The following is a description of a gene set: Human Gene Set: GOMF_MACROMOLECULAR_CONFORMATION_ISOMERASE_ACTIVITY studied in species Homo sapiens Catalysis of a reaction that alters the macromolecular conformation of a molecule., and this is the list of marker genes: TOP3A, MYH10, POLQ (NCBI Gene Id 29043), DDX55, FBH1, DDX11L8, DYNLRB1, RUVBL2, MYO15A, SPAST, SNRNP200, MYO9B, RFC4, CHD3, BTAF1, STARD9, KIF1C, DDX52, DDX17, MYO6, BLM, DDX28, CHD9, FXR1, WRNIP1, MYH7, KIF6 (kinesin family member 6), KATNA1, KIF17, DHX38, DDX25, CHD6, MYO3A, RAD54L, SPO11, DICER1, KIF4A, DHX15, DHX32, DQX1, KIF28P, RFC5, DNAI2, KIF1B, DDX12P, RUVBL1, DDX50, XRCC6, ASCC3, MYH1, DHX30, RTEL1, DDX51, KIF21A, RECQL5, CENPE, DDX1, KIF24, DDX54, YTHDC2, KIF13B, DDX59, DNAH8, KIF2C, MYL6, KIF12, FANCM, SMARCA4, MYO5C, DDX53, MYH3, ERCC6, KIF27, SMARCAD1, HFM1, PSMC4, CFTR (CF transmembrane conductance regulator), DDX24, SMARCA2, RAD54B, DNAH5, KIF1A, MYO1A, SKIC2, RAD51, DDX23, KATNAL2, TOP2B, KIF9, NAV2, KIF4B (kinesin family member 4B), DNAH9, MCM4, MCM5, MYO5B, KIF20B, KIF11, CHD7, PIF1, DHX37, TOP2A, SETX, CHD1, DNA2, TOP3B, TNNT2, MYO1H, MYO1C, MYH6, WRN, MCM8, MYH7B (myosin heavy chain 7B), KIF13A, MCM9, DNAH6, DDX3X, DNAL4, KIF2B, CHD8, DDX18, KIF3C, KIF18B, MYH2, DNAH1, KIF19, KIF23, DDX39A, KIF26A, MYO9A, IGHMBP2, EIF4H, RAD54L2, TP53, MCM7, ZRANB3, MRE11, MYH15 (myosin heavy chain 15), MYO1D, HELZ, DDX4, CHD4, KATNAL1, DDX3Y, KIF14, DHX36, SHPRH, MOV10, KIF18A, KIF3A, HELB, DDX27, DDX11, APPBP2, ZGRF1, DHX33, DNAH3, DDX60 (NCBI Gene Id 55601), FIGNL2, KIF22, CHD5, MYH13, IFIH1, TTF2, SRCAP, ERCC6L2, MYO7B, KIFC1, MYO1B, HELQ, MYH9, ERCC2, UPF1, PSMC2, DYNC2H1, AQR, ACTC1, DHX8, FMR1, SLFN11, MCM6 (minichromosome maintenance complex component 6), MCM2, EIF4A2, HLTF, DDX41, KIF5A, DNAH10, DHX29, IQCA1, DNHD1, TDRD12, EIF4A3, XRCC5, DDX56, DDX19A, DDX39B, DHX35, DDX19B, MYH4, DHX16, IQCA1L, DYNC1I2, TOP1, FIGNL1, RAD50, DSCC1, DNAH17, MYO3B, DNAH2, DDX21, FIGN, MOV10L1, PSMC1, KIF2A, PSMC3, DHX40, DDX47, KIF3B, DNAH12 (NCBI Gene Id 8679), DYNC1I1, EIF4B, DNAH14, MYO1F, RFC2, DDX6, KIF5B, CHD2, ATRX, TDRD9, DHX34, MYO7A, SMC3, CHD1L, MYO19, DHX57, EP400, MCM3, KIF26B, KIFC3, DDX5, HELLS, DDX10, KIF25, PSMC5, EIF4A1, DDX46, SMARCA5, DYNLRB2, ERCC6L, DNAH11, BRIP1, DDX42, KIF7, RFC3 (replication factor C subunit 3), ZNFX1, KIF5C, KIF21B, KIF16B, MYH11, CHTF8, TOP1MT, RECQL, MYH14, DHX58, DHX9, SMARCAL1, G3BP1, DDX31 (NCBI Gene Id 64794), KIF20A, SUPV3L1, DDX60L, DNAH7, SMARCA1, KIFC2, KIF15, MYO1G, DDX20, DDX43, MYO5A, MYH8, PSMC6, MYO1E, RIGI, MYO10, DDX49, DYNC1H1, CHTF18, HELZ2, ERCC3 (NCBI Gene Id 2071), MTREX, RECQL4, TWNK